The following is a description of a gene set: Human Gene Set: GSE2706_UNSTIM_VS_2H_LPS_AND_R848_DC_UP from publication Napolitani G, Rinaldi A, Bertoni F, Sallusto F, Lanzavecchia A (PMID 15995707) species: Homo sapiens Genes up-regulated in comparison of unstimulated dendritic cells (DC) at 0 h versus DCs stimulated with LPS (TLR4 agonist) and R848 for 2 h. Toll like receptors (TLRs) sense microbial products and initiate adaptive immune responses by activating dendritic cells (DCs). Since pathogens may contain several agonists we asked whether different TLRs may synergize in DC activation. We report that in human and mouse DC TLR3 or TLR4 potently synergize with TLR7, TLR8 or TLR9 in the induction of selected cytokine genes. Upon synergistic stimulation, IL-12, IL-23 and Delta-4 are induced at levels 50-100 fold higher than those induced by optimal concentrations of single agonists, leading to enhanced and sustained TH1 polarizing capacity. Using microarray analysis we show that only 1.5% of the transcripts induced by single TLR agonists are synergistically regulated by combinations of TLR4 and TLR8 agonists. These results identify a combinatorial code by which DCs discriminate pathogens and provide (suggest) a rationale to design adjuvants for TH1 responses. Series_overall_design: 3 untreated, 3 treated with LPS at 2h, 3 treated with LPS at 8h, 3 treated with R848 at 2h, 3 treated with R848 at 8h, 3 treated with LPS + R848 at 2h, 3 treated with LPS + R848 at 8h, and this is the list of marker genes: EMG1, CBFA2T2, ZBED5, CCR2, TRG-AS1, ANKRD20A11P, ZNF280B, FKBPL, STEAP2 (STEAP2 metalloreductase), C11orf87, ITPRIPL1, GRPEL2, ZNF689, ZNF717, MTHFSD, KCTD21, ZNF211, DOK1, KIAA0232, TSPYL6, DNAAF10, KLHL24, GPR31, NAIF1, USP10, TP53RK, LNX2, BUD13, CRYGA, BRD1, MTFR2, TCHP, RPL13P5, ZNF250, SCAF4, RBAK, MARF1, CSTF1, ZKSCAN4, TRIM32 (tripartite motif containing 32), PRR35, PAAF1, HNRNPU, RPP38, ZNF227, NOC3L, ID3, FRAT2, RFWD3, ZFP62, RRP8, ZNF500, PALS2, TIGD5, ZNF275, TRIM23 (tripartite motif containing 23), DDX28, POLG2, PHF23, KDM4A, TUBD1, MTERF1, CEP104, ZBTB41, LSG1, ZNF766, FDX2, TTC9C, ZBTB26, TAF5, ZCCHC3, ANKRD17, ZNF449, TMEM179B, RP9, RNF26, USP37, ZNF830, ZNF398, ENSG00000274253, CCDC18-AS1, TRMT13, ZNF14, PTCD2, ATG14, FADD, NLRC4, ZNF7 (zinc finger protein 7), CTLA4, EFNA3, ZNF787, ZNF451, TAFA1 (TAFA chemokine like family member 1), DDR1, ASB8, AGO3, NOB1, LINC02709, WRAP73, ZNF691, ZNF184, BAZ1B, DDIT3, RNF25, LUZP4, COA3, MSANTD2, KMT2A, KCTD6, THOC1, GTF2H1, GPR155, FOXQ1, KBTBD6, ZNF557, NSD1, LINC00324, PDCD7, ZNF646, ZNF641, WNT3, ZNF3 (NCBI Gene Id 7551), MRPS11, BRF2, PIGM (phosphatidylinositol glycan anchor biosynthesis class M), RSBN1, PARS2, LNPEP, ZNF813, MTMR4, ELAC1, FKBP4, HYLS1, PAN2, ZNF850, LUZP2 (NCBI Gene Id 378943), CNTN3 (NCBI Gene Id 57632), LRRC37B, MTMR3, ZNF322, ZC3H15, ZNF302, TRIM59, ITM2A, ZNF770, LINC02076, FDXACB1 (NCBI Gene Id 91893), DAGLB, ZNF324, TSC22D3, DZIP3, GNL3, CDK9, ZNF791, AGAP4, NBPF1, CFAP298, PRLHR, PPFIBP2, CCDC66, SH2D3C, PDIK1L, TAS2R40, CDAN1, MTF2, FAM118B, EIF4ENIF1 (eukaryotic translation initiation factor 4E nuclear import factor 1), TMEM150A, SOCS5, PRPF38B (NCBI Gene Id 55119), ZNF420, HHEX, BRAT1, ZNF148, CDKN1B, MRFAP1L1, ASPHD2 (NCBI Gene Id 57168), ZNF397, CRACDL, ZNF319, NKTR, MIRLET7D, ERCC4, ZNF775, CCDC102B, SNHG1, DACT1, SLC24A4, RNF113A, IER5L, VAMP1